Given this list of marker genes Cd80, Fyn, Lck, Vav1, Pak1, Cdc42, Pak3, Grb2, Rac1, Cd28, Cd86, Pak2, here is a description of the gene set: Mouse Gene Set: REACTOME_CD28_DEPENDENT_VAV1_PATHWAY CD28 dependent Vav1 pathway species: Mus musculus